The following is a description of a gene set: Human Gene Set: GOCC_DEATH_INDUCING_SIGNALING_COMPLEX A protein complex formed by the association of signaling proteins with a death receptor upon ligand binding. The complex includes procaspases and death domain-containing proteins in addition to the ligand-bound receptor, and may control the activation of caspases 8 and 10. species: Homo sapiens, and this is the list of marker genes: FAF1, CFLAR, TRADD, CASP3, FADD, CASP8, RIPK1, FAS, CASP10